The following is a description of a gene set: Human Gene Set: GOBP_REELIN_MEDIATED_SIGNALING_PATHWAY studied in species Homo sapiens The series of molecular signals initiated by the binding of reelin (a secreted glycoprotein) to a receptor on the surface of a target cell, and ending with the regulation of a downstream cellular process, e.g. transcription., and this is the list of marker genes: VLDLR, CRKL, FYN, CRK, FKRP, RELN, LRP8, DAB1, RNF7, CUL5, STAT5A, PAFAH1B1